Given this list of marker genes Emb, Junb, Btg2, Dusp1, Jund, here is a description of the gene set: Cytokines mediate cell-cell communication in the immune system and represent important therapeutic targets. A myriad of studies have highlighted their central role in immune function, yet we lack a global view of the cellular responses of each immune cell type to each cytokine. To address this gap, the authors created the Immune Dictionary, a compendium of single-cell transcriptomic profiles of more than 17 immune cell types in response to each of 86 cytokines (>1,400 cytokine-cell type combinations) in mouse lymph nodes in vivo. A cytokine-centric view of the dictionary revealed that most cytokines induce highly cell-type-specific responses. For example, the inflammatory cytokine interleukin-1β induces distinct gene programmes in almost every cell type. A cell-type-centric view of the dictionary identified more than 66 cytokine-driven cellular polarization states across immune cell types, including previously uncharacterized states such as an interleukin-18-induced polyfunctional natural killer cell state. from publication Cui A, Huang T, Li S, Ma A, Pérez JL, Sander C, Keskin DB, Wu CJ, Fraenkel E, Hacohen N (PMID 38057668) studied in species Mus musculus Mouse Gene Set: CUI_T_CELL_GD_TGF_BETA_1_RESPONSE_DN Genes negatively differentially expressed in cell type: γδ T cell upon treatment with cytokine: TGF-β1 in mouse lymph nodes in vivo.